Given this list of marker genes TEX14, MAD2L2, HNRNPA1, KATNB1, SLX1A, NUBP1, KANK3, ODF2L, PML (PML nuclear body scaffold), KNL1, BRCA1, FNIP1, EXOSC10, ERCC4, BOK, ZNF207, PPFIA1, SLC25A4, MET, PFN1, HSPA1A, SHANK1, TBCD, CLSTN3, LPAR1, CARMIL2, ARHGEF2, MID1, SWAP70, SSH1, NAT10, HORMAD1 (NCBI Gene Id 84072), F11R, AKT1, USP10, FLII, ATM, TINF2, YAP1, CYRIB, DIAPH3, ARAP1, MPV17L, ATRX, TRIAP1, VAT1, TMOD3, BCL2L1, RAD21, CARMIL1, BAK1, SPTB, ADD3, SETMAR, SEC22B, TMOD1, TACSTD2, BMERB1, MPHOSPH9 (M-phase phosphoprotein 9), GMFG, CKAP2, TRIM32, TP53, WASF2, CIB1, TOM1L1, CENATAC, LCMT1, SMG6, TEN1, ERCC1, EHMT2, RHPN1, SMARCA5, SPTAN1, LRRK2, RHPN2, HDGFL3, TENT4B, PRRT2, SLC25A31, CORO2B, SSH2, SCIN, TTBK2, MIR20A, FEZ2, DLC1, HNRNPC, PAK2, HASPIN, HGF, GPX1, OAZ3, VIL1, SPTBN5, DYNC1LI1, IFI6, PRKCD, KANK4, LMOD2, RTEL1, EPS8, USP44, FGF13, APC, PARP1, SCFD1, TAOK1, TRIP13, STYXL1, LILRB2, TOGARAM2, ADCK1, SLIT2 (NCBI Gene Id 9353), PSMD10, MTOR, BIRC5, ARHGEF18, PLK1, MCRS1, IQCJ-SCHIP1, MAPRE1, CLU, DYRK1A, GNL3L, PARL, SRC, TPX2 (NCBI Gene Id 23477), TBC1D4, BMP4, PRELID1, SPC25 (SPC25 component of NDC80 kinetochore complex), BUB1, RAB7A, BNIP3, CDC20, MAK, GCLC, SPTA1, TMEFF2, IGF1, INPP5K, FZD9, NPM1, MIR149, H3-3A, KNTC1, PATL2, SPECC1L, KLHL22, EML2, MAD2L1, KANK1, TERF2, SHANK3, FRMD7, FEZ1, TFRC, TMOD4, EVI5L, GMFB, PPARG (NCBI Gene Id 5468), GEN1, STMN2, TNKS2 (NCBI Gene Id 94771), NAA10, MDM1, POT1, NBN, ZW10, MYADM, SNCA, ANKRD27, CAPZA3, TERF1, LIMK2, STMN1, LMOD3, CTC1 (NCBI Gene Id 80169), CAPZB, CLASP1, SPTBN4, MAP1B, BMP7, RBM14 (NCBI Gene Id 96086), TJP1, SSH3, MAP2, LUZP1, GDI2, KIF24, TUBB4A, CAPZA1, CDH5, LIMA1, AVIL, SPC24, MAPT, GAS2L1, CORO1B, AURKB, NAV3, RHPN2P1, SKA3, TTK, CCDC88C, CEP97, ASB2, DMTN, TMSB4X, CCP110, PHLDB2, NUF2, RDX, KAT2B, NOL3, SPTBN2, SPTBN1, MIR214, WDR47, SVIL, MTPN, RAD50, NUPR1, SPDL1 (NCBI Gene Id 54908), KAT2A, NDC80, MTBP, MIR138-1, TMEM39A, OMA1, CAMSAP2, NME6, ACAA2, CRACD, ACD, TERF2IP, ADD2, MTM1, IER3, MIR21, HIP1R, HUWE1, PRKN, WASHC2C, ZWINT, CDCA8, PLEKHH2, DUSP1, PINX1, TPR, STN1, CGNL1, PSMG2, PRP4K, TRIOBP, SMCR8, TWF2, H3-3B, CHEK1, FXN, HIGD1A, APC2, SLC25A6, ESPL1, ANAPC15, PICK1, MAD1L1, MUL1 (mitochondrial E3 ubiquitin protein ligase 1), BECN1, KANK2, RPS6KA2 (ribosomal protein S6 kinase A2), ARPIN, SLX1B, MAP4, DCP2, TWF1, INCENP, MID1IP1, WDR44, XRCC1, FKBP4, ARFGEF1, LIF, NANOS2, GSN, PPIF, GAS2L2, FBXO5, CAPG, ARHGAP6, TRIM37, ZWILCH, TNKS, TBC1D7, ARHGEF7, CDK10, MAD2L1BP, BUB3 (NCBI Gene Id 9184), SMAD4, GHITM, PARP3, PIF1, CCNB1, CDK5RAP2, CFL1, TMEM14A, TOM1L2, CTNNA2, FBXO43, BBS4, ARHGAP28 (Rho GTPase activating protein 28), S1PR1, CAV3, CLIP3, TBC1D30, C11orf65, RAD1, DMRT1, PINK1, BUB1B, IK, SLC25A5, SPEF1, PHF23, ADD1, OPA1, BAZ1B, WAS, HNRNPU, PIK3R1, SKA1, CAPZA2, CENPF, XRCC3, TMOD2, VILL, HDAC6 (histone deacetylase 6), MARCHF7, SLC35F6, LMOD1, XRN1 (NCBI Gene Id 54464), MKKS, PRAP1, MAP6D1, TCHP, BBOF1, TMEM67, TRIM54, MYOC, NBDY, WAPL, INPP5J (inositol polyphosphate-5-phosphatase J), TESK1, SLX4, ATXN7 (ataxin 7), AURKAIP1, PFN2, LMNA, CCNF, DNAI3, PIK3CA, CLASP2, CORO1A, FLCN, here is a description of the gene set: species: Homo sapiens Any process that decreases the frequency, rate or extent of a process involved in the formation, arrangement of constituent parts, or disassembly of an organelle. Human Gene Set: GOBP_NEGATIVE_REGULATION_OF_ORGANELLE_ORGANIZATION